Given this list of marker genes FOXG1, PTEN, TET2, DHX9, MBP, ARHGEF26 (NCBI Gene Id 26084), IGF2, E2F1, TET3, MTOR, RPS6, MEF2C, MYT1, UBE3A, PSIP1, SMC3, POU3F2, GRIA4, CREB1, NCOR1, GAD1, SP1, DLX5, APOC2, CDON (NCBI Gene Id 50937), HDAC1, PRPF38A, MAG, FGF2, SIN3A, TAF1, TAP1, HNRNPH1, HNRNPF, GRIN1, NREP, FKBP5, MPP1, CTCF, SST (somatostatin), CEBPD, FGF4, EZH2, SGK1, GRID1, FGF3 (fibroblast growth factor 3), NF1, MECP2, BDNF, DLX6, CSRP1, CNP, RBFOX1, TET1, GAMT, OPRK1, FUS, IGF1R, FGF5, TARDBP, GABRR2 (gamma-aminobutyric acid type A receptor subunit rho2), REST, IGF1, POU4F1, GRIA3, FUT8, GPRIN1, BCL6, AKT1, YBX1, CAMK2A, SP3, GRIA1, here is a description of the gene set: Human Gene Set: WP_MECP2_AND_ASSOCIATED_RETT_SYNDROME MECP2 and associated Rett syndrome studied in species Homo sapiens